The following is a description of a gene set: The CD4+Foxp3+ regulatory T cells play an essential role in maintaining tolerance via their suppressive function on conventional T cells. The intracellular signaling pathways that regulate Foxp3 expression are largely unknown. In this study we describe a novel inhibitory role for AKT in regulating de novo induction of Foxp3 both in vivo and in vitro. A constitutively active allele of AKT significantly diminished TGF-â induced Foxp3 induction via a rapamycin-sensitive pathway, establishing a role for the AKT-mTOR axis in Treg cells. Moreover, the observed impairment in Foxp3 induction was paralleled by a selective downmodulation of the imparted Treg transcriptional signature highlighting the importance of the balance of intracellular signals in Treg differentiation. Our results provide a basis for further elucidation of molecular mechanisms that regulate Foxp3 induction and identify AKT as an important negative regulator of this process. Human Gene Set: GSE7596_AKT_TRANSD_VS_CTRL_CD4_TCONV_WITH_TGFB_DN species: Homo sapiens from publication Haxhinasto S, Mathis D, Benoist C (PMID 18283119) Genes down-regulated in T conv in response to TGF-beta: expressing constantly active form of AKT1 versus control., and this is the list of marker genes: AVP, EIF3K, TLE2, PDE9A, C19orf38, PALLD, SMPX, PROK1, ARL4C, CHAC1, MARCHF7, RNF39, WNT3, SERPINE2, ALOX12, SNHG1, TRMT1, PADI4, TPD52, LIX1, ACY3 (NCBI Gene Id 91703), LETM2, STEAP2, EZHIP, PGC, RBM47 (NCBI Gene Id 54502), LSAMP, TMEM41A, KLRG2, BPIFB1, COL4A4, SEL1L3, SCRT1, ADH1A, TMSB10, MIR219A1, TRPM1, ASPRV1, TMEM169, MARCHF1, TSHZ3, CDH5, HLF, TTC22, HS3ST3B1, GNAI1, CNBD1, SDHC, PRRG4, GOLGA7B, H2BL1P, POTEG, CD109, MPP3, LRRN2, ZGLP1, DYNC1H1, NSG2, LTB4R, MARVELD1, CIMAP1B, CTDSPL, CMTM3, PPP1R1A, GPR183, CHRNB3, DSCAM, EYA2, PHEX, EARS2, SPINT4, HIPK4, GJA1, TMEM205, ANKRD7, ALKAL1, TACR1 (NCBI Gene Id 6869), ZDHHC12, NEK8, RPUSD1, KCTD11, ACY1, TBC1D1, GPR158, EBI3, CCL4, ANKRD61, TNR, OOSP1 (NCBI Gene Id 255649), EFCAB9, TEX15, FAU, HMGA2, NTN4, IGSF9, CCDC136, UPK3B, NAP1L5, GPR85, TBX2, HOXB3, TTC16, TMEM86A, TMPRSS15, HAS1, IGHG3, IVD, COL15A1, SH3RF2, FGD6, SIX5, KRT19, NOP53, CBLIF, CTSL, TSPAN1, MEF2C, PDK4, SNN, RPS4Y2, CSRP3, NRTN, LMX1B, NKX3-1, CDHR2, ENGASE, SPRR2F (small proline rich protein 2F), NRROS